Given this list of marker genes UBA6, SCOC, H2AC6, LIFR, SLC12A2, UVSSA, RBPJ, APCDD1L, DNAJB14, NPIPB4, DCAF16, COL6A3, AOPEP, KHDRBS3, TALAM1, LIMCH1, KIAA0232 (KIAA0232), PTGER4, QKI, ATP10D, MED31, C5orf24, TNC, INSIG1, ZC2HC1A (zinc finger C2HC-type containing 1A), GPX8, SHC3, PPP3CA, RAB28, HSPA1B, GPAT3, ADH5, NPIPB13, MYO10, TMEM106B, NAA15, ETV1, SLC25A37, PPP2R5C (protein phosphatase 2 regulatory subunit B'gamma), CTSB, STC1, PHACTR2, RELL1 (NCBI Gene Id 768211), PTN, CDKN2AIP, HSPA1A, FUS, LNPEP, ACOT13, UBE2K, SLC16A7, FAT1, DSE, ZRSR2, ITGB8, RBMS1, BICC1, MCTP1 (NCBI Gene Id 79772), STEAP1 (STEAP family member 1), WDFY3, SEC24D, DMXL1, SEPTIN11, SRSF3, here is a description of the gene set: Genes down-regulated in MDA-MB-231 cells (breast cancer) upon overexpression of PARVB under all three culture conditions. from publication Johnstone CN, Mongroo PS, Rich AS, Schupp M, Bowser MJ, Delemos AS, Tobias JW, Liu Y, Hannigan GE, Rustgi AK (PMID 17998334) Parvin-beta is a focal adhesion protein downregulated in human breast cancer cells. Loss of Parvin-beta contributes to increased integrin-linked kinase activity, cell-matrix adhesion, and invasion through the extracellular matrix in vitro. The effect of ectopic Parvin-beta expression on the transcriptional profile of MDA-MB-231 breast cancer cells, which normally do not express Parvin-beta, was evaluated. Particular emphasis was placed upon propagating MDA-MB-231 breast cancer cells in three-dimensional culture matrices. Interestingly, Parvin-beta reexpression in MDA-MB-231 cells increased the mRNA expression, serine 82 phosphorylation (mediated by CDK9), and activity of the nuclear hormone receptor peroxisome proliferator-activated receptor gamma (PPARgamma), and there was a concomitant increase in lipogenic gene expression as a downstream effector of PPARgamma. Importantly, Parvin-beta suppressed breast cancer growth in vivo, with associated decreased proliferation. These data suggest that Parvin-beta might influence breast cancer progression. Human Gene Set: JOHNSTONE_PARVB_TARGETS_1_DN species: Homo sapiens